Given this list of marker genes MRAS, ZCCHC24, UBE2Z, OSMR, AEBP1, PCDHA9, GFRA1, DPCD, USP31, TPM1, HOMER3, C1S, RPL27, CTTNBP2NL, ZEB2, TPBG, ADGRG1, RGS1, SOAT1 (sterol O-acyltransferase 1), ANTXR1, GPNMB, MYRF, ISLR, P4HB, CYFIP1, TM4SF18, HIKESHI, CTHRC1, PPP1R14A, CLDN3, RPN2 (NCBI Gene Id 6185), VTCN1, RBMS3, ITPR3, ACER3, C3, CHRNA3, TMPRSS4, LACC1 (laccase domain containing 1), MOXD1, MIOS, BHLHE41, GGT5, STS, C1QC, SOCS3 (NCBI Gene Id 9021), ARHGAP1, ZMAT3, FCAMR, RHEX, POLE4, LINC02086, KIRREL1, RAD54L, TPSAB1 (tryptase alpha/beta 1), MFGE8, COL1A2, SERPINE2 (serpin family E member 2), NR2F1, MGLL, SLC1A3, SERPINH1, CCL2, RPS27L, ERICH3, SLC46A3, PROM1, FHL1, SYTL2, STAB1, RPN1 (NCBI Gene Id 6184), RPS10, LDLRAD4, RNF213, DRAM1, VASH2, MCAM, ABI3BP, RARRES1, RPL35, ANXA2, TBCB, A2M, PKIB, RPS25, CXCL14, C7, GABBR1, ZNF783, RFTN1, ITGA1, ADCY10P1, ASNS (asparagine synthetase (glutamine-hydrolyzing)), FEZ2, MICALL2, CKAP4, RPL22L1, NFKBIZ, COL3A1, SLC40A1, MYOF, MMP11, INHBA, ANXA1, AMBP, CCN3, DLGAP1, TFPI, IGHV3-47, SMPD2, LEPROT, CDC42EP1, HGF, PGM2L1, COL14A1, TRIL, TMEM243, TIMP1, TNC, WFDC2, AATF, ANXA2P3, TXNDC5, LUM, CALU, PDGFC, B3GAT3, ALPK2, FBN1, VCAM1, GABRP, TMEM200A, SNORA70, TSPAN1, ABCC3, ITM2C, HAVCR1, MAP4, CDH11, RBP1, MSR1, FN1, VSNL1, OCLNP1, MMP7, ADRA2A, PXDN, NNMT, DKK3, PGGHG, CAVIN1, GPX8, PAPPA2, C1R, PHLDA3, TMED3, ZFAS1, TRIM47, SPON1, SERPING1, CRELD2, CXCL6, PDIA4, SCN5A, SETD7, C1QA, LOXL1, CDO1, NUAK1, CDH6, COL15A1, DCDC2, CLDN1, SYMPK, POLR1D, VEGFC, COL5A1, LIX1, PLOD3, FIBIN, DEGS1, GPR61, CFB, PPP1R14B, VARS1, MIR34AHG, PRICKLE1, KCND3, RAB34, MYDGF, PIGR, PRUNE1, TIMP2 (TIMP metallopeptidase inhibitor 2), NFIX, ITGB6, FSCN1, PAM, SPTLC3, SPARCL1, LTF, RPL35A, TNFRSF11B, COL6A3, CXCL2, ANTXR2, MTHFD1L (NCBI Gene Id 80244), COL1A1, AIDA, SSR4, PLK2, AXL, MRC1, HEXB, DPP3, IFI27L2, PRB1, RPL12, ATL3, COL27A1, TAGLN (transgelin), C4A, GGTA1, C1QB, here is a description of the gene set: Genes whose expression increases with age in normal kidney, excluding those with higher expression in blood. In this study, we found genes that change expression in the cortex and the medulla of the kidney with age. Some of the genes whose transcripts increase in abundance with age are known to be specifically expressed in immune cells, suggesting that immune surveillance or inflammation increases with age. The age-regulated genes show a similar aging profile in the cortex and the medulla, suggesting a common underlying mechanism for aging. Expression profiles of these age-regulated genes mark not only age, but also the relative health and physiology of the kidney in older individuals. Finally, the set of aging-regulated kidney genes suggests specific mechanisms and pathways that may play a role in kidney degeneration with age. Human Gene Set: RODWELL_AGING_KIDNEY_NO_BLOOD_UP studied in species Homo sapiens from publication Rodwell GE, Sonu R, Zahn JM, Lund J, Wilhelmy J, Wang L, Xiao W, Mindrinos M, Crane E, Segal E, Myers BD, Brooks JD, Davis RW, Higgins J, Owen AB, Kim SK (PMID 15562319)